The following is a description of a gene set: from publication Gao S, Yan L, Wang R, Li J, Yong J, Zhou X, Wei Y, Wu X, Wang X, Fan X, Yan J, Zhi X, Gao Y, Guo H, Jin X, Wang W, Mao Y, Wang F, Wen L, Fu W, Ge H, Qiao J, Tang F (PMID 29802404) species: Homo sapiens Human Gene Set: GAO_LARGE_INTESTINE_24W_C4_PROM1LOW_PROGENITOR, and this is the list of marker genes: PART1, PTGES3L, SGCA, ALCAM, RAB9B, GJC1 (NCBI Gene Id 10052), MEIS3